Given this list of marker genes Gstp2, Gstp3, Gsta13, Gstp-ps, Gsta1 (glutathione S-transferase, alpha 1 (Ya)), Gsta5 (NCBI Gene Id 235501), Gstp1, Gsta2 (glutathione S-transferase, alpha 2 (Yc2)), here is a description of the gene set: Mouse Gene Set: GOMF_DINITROSYL_IRON_COMPLEX_BINDING Binding to a dinitrosyl-iron complex. Nitric oxide (NO) is stored as dinitrosyl-iron complexes, which form spontaneously from Glutathione (GSH), S-nitrosoglutathione, and trace amounts of ferrous ions, or by reaction of iron-sulfur centers with NO. studied in species Mus musculus